The following is a description of a gene set: studied in species Homo sapiens from publication Fan X, Bialecka M, Moustakas I, Lam E, Torrens-Juaneda V, Borggreven NV, Trouw L, Louwe LA, Pilgram GSK, Mei H, van der Westerlaken L, Chuva de Sousa Lopes SM (PMID 31320652) Human Gene Set: FAN_OVARY_CL10_PUTATIVE_EARLY_ATRESIA_GRANULOSA_CELL The GC of CL10 were negative for several GC markers, such as VCAN and FST (Fig. 4b), but were also negative for KRT18 (Fig. 4b), similarly to pan-KRT-negative GC in atretic follicles (Fig. 4d). This suggested that CL10 could represent GC in the early stages of atresia., and this is the list of marker genes: ATP5MC2, NDUFS4, PSMC3, UQCRQ, POLR2L, CBX3, ACTG1, NDUFS6, GABARAP, PLA2G12A, SERF2, UQCR10 (NCBI Gene Id 29796), POLR2I, SERPINE2, PEBP1, ARPC5, PSMD4, ID3, HMGN2, RPL36A, HSD17B1, TMEM14A, SKP1, HNRNPA1, APEX1, PPP1R14A, MDK, TPI1 (NCBI Gene Id 7167), GSTA1, UROS, AP2S1, MZT2A, EEF1G, SF3B6 (splicing factor 3b subunit 6), CALM2, NDUFB11, GSTA4, SRP9, AMH, SRSF9, ATP5F1A, PPP1CA, CLIC1, SUMO2, MRPL16, HMGB2, NDUFA2, RPS17, LSM3, DDX24, ALDOA, NDUFA7 (NCBI Gene Id 4701), ST3GAL4, RAN, PYURF, FSCN1, COPS6, PRDX3, TUBA1A, BANF1, SOX4, RPL35, BEX1, RANBP1, ZNF428, NDUFB8, PSMA7, SNRPN (small nuclear ribonucleoprotein polypeptide N), SEM1, NDUFA12, POMP, UBL5, S100A16, NDUFA1, PHPT1, APRT, ATP5ME, HINT1, COPS9, ATP5MJ, PPP4C, MGST3 (microsomal glutathione S-transferase 3), OST4, GTF2H5, TUBB, SRP14, MDH2, COPE, SNRPD1, NDUFV2, RPS19, BTF3L4, COX7A2, TIMM13, IFI27, PHF6, H2AZ1, RPS25, TUBA1B, VDAC1, MACROH2A1, SRI, MAGED2, CALM3, PHB1, APOA1, POLR2F, ANAPC11, SLC25A6, COX8A, PSMB7, NDP, ACTB, GATM, SELENOH (selenoprotein H), SSBP1, PRDX2, COX5A, ATP5MK (ATP synthase membrane subunit k), COX5B, NDUFA13, EAPP, ANXA6, DYNLL1, SLIRP, TCEAL9 (NCBI Gene Id 51186), TCEAL8, MEAF6, PLIN3, MRPL51, COX7C, TBCB, S100A10 (S100 calcium binding protein A10), TMSB10, PSMC1, SLC25A5, TMEM97, CYC1, TMEM258, NDUFC2, MPST, SDHC, DMAC1, NME1, PTMA, CFDP1, GADD45GIP1, RBP1, EIF3L, SNRPC, DNPH1 (NCBI Gene Id 10591), ROMO1, MRPS21, TCEA3 (NCBI Gene Id 6920), GSTP1, ATP5IF1, LSM7, ARPC3, MICOS10, RBX1, PSMB5, STOML2, MORF4L1, PKM, SNRPD2, H3-3A, DUT, PARK7, CFL1 (cofilin 1), NDUFB7, ELOB, PTRHD1, CKB, TMSB4X, LY6E, IDH1, PRMT2, ECH1, TNNI3, LDHB, ATP5PF, CWC15, MARCKSL1, NME4, HDAC2 (histone deacetylase 2), CSTB, RPS14, GRIK1, NDUFS5 (NCBI Gene Id 4725), CLNS1A, NDUFB2, CAMTA1, RPL3, ATP5PO, DDAH2, PSMB3, PIN1, PPDPF, PDCD5, COX6B1, MGARP, HSBP1, ERH, NDUFA4, MZT2B, CIAO2B, PSMA4, LCMT1, PRDX5, ECHS1, SPINT2, PSMB6, AURKAIP1, ATP5F1B, FDXR, NDUFA3, ARPC2, PSMA3, MYL6, SPRR2F, PFN1, NDUFAB1, GAPDH (glyceraldehyde-3-phosphate dehydrogenase), TMA7, NDUFS8, TSPAN6, AP2M1, SMARCB1, HMGN1, TBCA, DGUOK, CD99, FHL2, PLEKHJ1, PSMB2, TRMT112, COX4I1, SNRPF, HMGB1, NHP2, BEX3, ATP5MF, LSM4, NDUFB4, VDAC3, SNRPG, NDUFA11, HIGD2A, ATP5F1E, TRAPPC4 (NCBI Gene Id 51399), NDUFC1, BEX4, SMS, UQCR11, DBI, LSM5, YWHAE, PRSS23, SNRPE, GNG5, ATP5MG (ATP synthase membrane subunit g), DYNLT1, RPS27L, ATP5MC3, PLAAT3 (NCBI Gene Id 11145), ATP5F1C, VPS29, MYL12B, MDH1, NEDD8, NDFIP1, ATP5MC1, STMN1, GPX3